The following is a description of a gene set: Human Gene Set: GSE40666_WT_VS_STAT1_KO_CD8_TCELL_UP studied in species Homo sapiens from publication Gil MP, Ploquin MJ, Watford WT, Lee SH, Kim K, Wang X, Kanno Y, O'Shea JJ, Biron CA (PMID 22968462) Type 1 IFNs can conditionally activate all of the signal transducers and activators of transcription molecules (STATs), including STAT4. The best-characterized signaling pathways use STAT1, however, and type 1 IFN inhibition of cell proliferation is STAT1 dependent. We report that type 1 IFNs can basally stimulate STAT1- and STAT4- dependent effects in CD8 T cells, but that CD8 T cells responding to infections of mice with lymphocytic choriomenigitis virus have elevated STAT4 and lower STAT1 expression with significant consequences for modifying the effects of type 1 IFN exposure. The phenotype was associated with preferential type 1 IFN activation of STAT4 as compared to STAT1. Stimulation through the TCR induced elevated STAT4 expression, and STAT4 was required for peak expansion of antigen-specific CD8 T cells, low STAT1 levels, and resistance to type 1 IFN-mediated inhibition of proliferation. Thus, a mechanism is discovered for regulating the consequences of type 1 IFN exposure in CD8 T cells, with STAT4 acting as a key molecule in driving optimal antigen-specific responses and overcoming STAT1-dependent inhibition of proliferation. Genes up-regulated in CD8 T cells: wildtype versus STAT1 knockout., and this is the list of marker genes: SPSB1, NYAP1, ACTN1, SH3GL1, ABTB2, FAM168A, THEMIS, CBX4, TMCC1, IKZF4, ELOVL7, SORL1, FRY, CACNA2D4, CIC, FMNL3, RIPOR2, UBALD2, PPP1R12B, F13A1, CEP57L1, STAT5B, TLE2, TM7SF2, ADGRG3 (adhesion G protein-coupled receptor G3), RTN4RL1, HLA-DOB, F8 (NCBI Gene Id 14069), KIF24, ADD1, EDEM1, BACH2, MYO10, WASF2, RALGPS2, POU4F3, NHERF1, IL17RA, PARD6G, FNBP1L, MSH6, RASA3 (RAS p21 protein activator 3), ERCC5, IFIT1B, ARAP2, SRSF3, SATB1, PIP4K2A, TBC1D14, POGZ, SPINDOC, GIMAP7, LMNA, PRKCB, ARHGEF10, SLC35D1, KLF13, INF2, ATG13, LRR1, CACNB3, BCL11B, ESYT2, ALS2CL, PELI1, GPR174, INTS7, LRBA, GALNT6, ST3GAL1, NIM1K, STAT5A, RAB3IP, GIMAP4, EPHB6, BCL3, NCOA1, L3MBTL3, ZDHHC15, TIPARP, BIRC3, TMEM71, BICD2, KLF7, DOCK11, SLC35D2, NECAB3, MTSS1, PCED1B, LETM2, N4BP2, KIAA0040, TNIK, FAM78A, MAPK11, CLIC4, SUSD6, PCGF5, TUBB2A, MARCHF7, SUN1, KREMEN1 (kringle containing transmembrane protein 1), PCYT1A, AS3MT (NCBI Gene Id 57412), PTGIR, ADCY6, BICDL1, HCFC2, EIF1 (eukaryotic translation initiation factor 1), DEDD2, ZFYVE28, KCNH2, LYST, PHF6, FOXP1, ARHGDIB, FAM117A, TMIE, SMC6, UNC5CL (unc-5 family C-terminal like), DLG3, DAPK1, SOX4, S1PR1, ZC3H12D, PLXND1, INPP5A, WBP2, ASXL2, MS4A6A, IPPK, DENND2C, PRSS16, TRAF4, RAPGEF4, DUSP10, STK4, LYPD6B, KIF3C, NR4A3, RBM38 (RNA binding motif protein 38), PER2, SLC16A5, BRDT, SLC25A27, FLNB, KLC3, TBC1D1, VANGL2, KCNN4, WEE2, SELENOP, ARHGAP29, MFHAS1, IRF9, ZBTB18, SMC4, BCLAF3, SIPA1L1, PIK3C2A, TMEM120B, TRIB2, CEP97, RELT, ARMCX1, LAT, NDRG1, UBASH3A, TULP3, CA2, SKI, ZNF281, PPM1K, NCK2, DGKD, NRIP1, EZR, GIMAP6 (NCBI Gene Id 79765), LRP12 (LDL receptor related protein 12), PPP1R14C, INPP5F, GPRASP2, SYTL2, MX1, TMCC3, BBS9, KLHL18, DZIP1, MAPK7, XPO6, LRATD2, IFT80, ZNF597, TUBB, CCDC22, ARHGAP33 (NCBI Gene Id 93092), IL4R, RBL1, BCL6, CCM2